The following is a description of a gene set: The creation of greater cell numbers in the forebrain due to cell division of progenitor cells. studied in species Homo sapiens Human Gene Set: GOBP_CELL_PROLIFERATION_IN_FOREBRAIN, and this is the list of marker genes: FGFR1, AKNA, HMGA2, POU3F3, HOOK3, FGF8, ARX, WNT7A, DIXDC1, ZEB2, NUMBL, DOCK7, DCT, NFIB, LHX5, WNT3A, FGFR2, POU3F2, NUMB, IGF2BP1, GLI3, KIF14, EMX2, CEP120, RRM1, SIX3, DISC1, PCM1